The following is a description of a gene set: Human Gene Set: GSE46606_UNSTIM_VS_CD40L_IL2_IL5_1DAY_STIMULATED_IRF4MID_SORTED_BCELL_DN Genes down-regulated in at day 0 B cell IRF4-KO versus CD40L and IL-2 IL-4 IL-5 stimulated at day 1 B cell IRF4intermediate. Temporal analysis of B cell activation in vitro using CD40L and IL-2/4/5 cytokines in wild type Irf4+/+ B cells or in mutant Irf4-/- B cells harboring a tet-inducible allele of Irf4. IRF4 expression was restored, or not, in the Irf4-/- background by culturing in the presence of low or high concentrations of doxycycline. The results provide insight in the role of IRF4 expression levels in coordinating different programs of B cell differentiation. from publication Ochiai K, Maienschein-Cline M, Simonetti G, Chen J, Rosenthal R, Brink R, Chong AS, Klein U, Dinner AR, Singh H, Sciammas R (PMID 23684984) species: Homo sapiens, and this is the list of marker genes: ATRAID, TMEM117, AGRP, KCNV1, ZNF418, KRTAP15-1, ATP5F1B, TMEM167A, ACP6, ATP2B2, CLEC1A, FANCB, PRKAG1, CHL1, GBA1, PHLDB2, TALDO1, TMC1, YBX2, IL11, WDR73, AGO3, MEIOB, PSME1, TMEM120B, COX6A2, PSMB1, ECH1 (enoyl-CoA hydratase 1), HOXD9, PPP6R2 (NCBI Gene Id 9701), HAUS3, CCL1, ERG28, CD3E, LHCGR, EBF4, ERP29, DAB1, PHEX, MNX1, VANGL1, SYT11, RAMP1, SSR4, FRMPD3 (FERM and PDZ domain containing 3), DDX55, NSUN7, EPHA1, PROSER2, NOP53, NKX2-5, RPS23, PIRT, AJM1, SLC7A14, SUN2, RPL6, CCN3, LRRC38, KRT73, SPPL3, CNTN1, NAA20, MFSD9, SEC14L5, MIR124-1HG, SNUPN, UGT2A3, ALKBH4, AKAIN1, NECTIN3, FMO2, CACFD1, CORIN, TMEM184A, SMDT1, MUSTN1, EFNA5, RPL4, MEF2B, PRAMEF25, SUPT4H1, ARMC8, CPNE4, CPNE8, TMEM114, FBN2, RNF151, TRARG1, CSDC2, MIXL1, ABHD17A, KLRC2, MRPL46, UROC1, EARS2, ALDH5A1, TTC9B, SPACA9, CTRC, TRMU, CXCL6, ERAP1, MACROH2A2, ITGB6, CPM, CD96, PCDHB14, NDUFB6, PDRG1, IGSF11, SORCS3, RIMBP3C, NAPA, ZNF563, NUDT13, KLHDC3, CFTR, IPPK, SOWAHA, HAPLN4, DPYSL4, KRTAP4-7, SLX4 (NCBI Gene Id 84464), TGFB1I1, MMP11, NINL, PPIA, SPRYD4, GABRQ, SH3RF2, CLDN1, TLR8, BMP4, EOLA1, KITLG, CAPNS1, SPRING1 (SREBF pathway regulator in golgi 1), COX4I1 (NCBI Gene Id 1327), LYZL1, PRELP, TSEN34, RAC2, SFTPD, ROPN1, ACTR3B, TLR4, GMPR, NME3, SCAI (suppressor of cancer cell invasion), GABRG2, PRKD1, FAT3, MRPL49, TBX18 (NCBI Gene Id 9096), PNPLA1, RPL3 (NCBI Gene Id 6122), RND2, ADAMTS15, TGIF2LX, PRR27, DBNDD2, FAM90A13, PGC, CCDC141, PIK3IP1, EHD2, ECRG4, FAXC, STX4, NUDT18, DDX39B, RANBP3L, SHROOM1, PDHA2, HSF2BP, COPZ1, MRPL43, TMEM37, CFHR2, UGT2B17, FGF20, NOL4, ASB5, TPRG1, ARIH2OS, PKD2L1, EID2, PDC, ZMYND12, SMPD5, CD37, CES3, NPEPL1, SAP30BP, HIVEP2, CFAP161, ITGA3, POU2AF1, UPB1